The following is a description of a gene set: Any process that decreases the rate, frequency, or extent of a change in state or activity of a cell (in terms of movement, secretion, enzyme production, gene expression, etc.) as a result of a growth factor stimulus. Human Gene Set: GOBP_NEGATIVE_REGULATION_OF_CELLULAR_RESPONSE_TO_GROWTH_FACTOR_STIMULUS species: Homo sapiens, and this is the list of marker genes: MTMR4, SOSTDC1, SFRP1, FZD1, HTRA1, TRIM33, SKOR2, MIR15A, UBE2D1, MIR29B1, AGTR2, VWC2L, SULF2, PTPN1, IL12B, ADGRA2, MIR210, IL12A, MIR200C, NOG, SFRP2, PDCD6, MIR100, TMEM53, TWSG1, CHRDL1, DKK1, HGS, MIR199B, CRIM1, SPRY1 (NCBI Gene Id 91129), MIRLET7B, CFLAR, FBN1, FSTL3, GATA3, IL4, CHRDL2 (NCBI Gene Id 25884), EMILIN1, MIR106A, MIR19A, MIR302B, SPRY2, GREM1 (NCBI Gene Id 7947), MMRN1, SPART, MIR376C, MIR214, LEMD3, CXCL13, SPRY3, CER1, TNFAIP6, MIR342, FGF2, ADAMTS12, BAMBI, UBE2D3, MIR302C, ABL1, TMPRSS6, NGFR, DAND5, HIPK2, DCN, HHEX, APLN, AGT, MIR573, WNT4, MIR149, MIR98, MIR16-1, MIR93 (NCBI Gene Id 407050), SKI, DAB2IP, MIR199A1, SKIL, PIK3CB, MIR19B1, MICOS10-NBL1, SULF1, SORL1, MIR26A1, RBPMS2, SEMA6A, THBS1, PPM1A, MMRN2, WNT5A, SHISA2, MIR125B1, OFD1, GPR155, PRDM14, MIR329-1, MIR424, FUZ, SMURF2, SOST, NR2F2, EPN2, CASK, VWC2, SMAD7, MIR20A, ANGPT1, GDF3, ERFE, MIR18A, CAV1, TOB1, GPC1 (glypican 1), SPRY4, DLX1, SKOR1, LRP2, HRG, NBL1, MIR195, ATP2B4, CTDSPL2, SMAD6 (SMAD family member 6), CREB3L1 (cAMP responsive element binding protein 3 like 1), SLIT2, SMURF1, MIR372, WNT1, NOTCH1, CHRD (chordin), HJV, MIR145, MIR885, MIR503, GREM2, CADM4, MIR204, PPARG, BMPER, NEDD4, MIR1-1, HTRA3